The following is a description of a gene set: The biological process involved in maintaining the steady-state number of cells within a population of free-living cells such as the bacteria in the gut. Human Gene Set: GOBP_HOST_MEDIATED_REGULATION_OF_INTESTINAL_MICROBIOTA_COMPOSITION studied in species Homo sapiens, and this is the list of marker genes: LRRC19, MUC2, CX3CR1, SPRR2A, ST6GALNAC1, NAPEPLD, CARD9, EPG5, NOD2, NLRP6